Given this list of marker genes TP53 (NCBI Gene Id 7157), CCNE2, MIR663B, MIR339 (microRNA 339), MIR95, here is a description of the gene set: Human Gene Set: WP_ULTRACONSERVED_REGION_339_MODULATION_OF_TUMOR_SUPPRESSOR_MICRORNAS_IN_CANCER studied in species Homo sapiens Ultraconserved region 339 modulation of tumor suppressor microRNAs in cancer